Given this list of marker genes HPSE, NAGLU, GUSB, GNS, HYAL2, GLB1, HGSNAT, GALNS, SGSH, HYAL4, HEXB, IDUA, HYAL1, ARSB, HPSE2, HEXA, IDS, here is a description of the gene set: Glycosaminoglycan degradation Human Gene Set: WP_GLYCOSAMINOGLYCAN_DEGRADATION studied in species Homo sapiens